Given this list of marker genes RND3, RELB, SYK, RELA, PILRA, WNT6, SLC31A2, CCL22, FAS, SLC12A5, SMPDL3B, SUSD6, IRAK3, MMP14, VASP, CYSRT1, SNX10, OSBPL3, GNAT2, EEIG2, GSR, NFKBIE, ZBP1, SEPTIN12, NFE2L1, HCAR2, FOXN2, PIK3R6, SLC34A2, N4BP1, BCL2A1, CHRM3, SLC7A11, CLDN6, RGS9, LZTFL1, NHERF4, CFP, CAMKK1, VTI1A, RAB11FIP1 (NCBI Gene Id 80223), NXPE3, FGF23, EXOC3L4, IRF7, USP13, CFLAR, RALGDS, CEBPD, TNFAIP3, SOD2, KMT5A, PIK3CG, TRIM13, SLAMF8, ARHGEF3, TANK, TNNT1 (troponin T1, slow skeletal type), SPRN, PAQR6, NODAL, OLR1, PRRG3, KLF7, EHD1, CD69, C3, RHBDF2, CLEC5A, SAA2, UBAC2, ZDHHC5, VAMP8, SLC2A1, ADORA2A, PTPN12, SH3BP4, TMEM170B, GSC2, MLLT6, WNT7B, NOD1 (nucleotide binding oligomerization domain containing 1), ATP5PO, ZC3H12C, NLRP3, MEFV, PGPEP1L, NFKB2, TNIP1, FILIP1L, PSMD10, DNAJC22 (DnaJ heat shock protein family (Hsp40) member C22), LYPD2, STRA6, PROB1, LRP3, USPL1, GSAP, TNF, CHIC1, LELP1, ASS1, PTPN23, RAB32 (NCBI Gene Id 10981), ADRB3, ABRACL, PRRT1, IFT57 (intraflagellar transport 57), PNP, AQP12A, GOLGA7B, CACNG8, DUSP16, TP63, NUP54, ARK2C, TMA16, LMO4, GCH1, ASB6, CXCL10, CFB, GNG12, CHST1, HDC, NEK5, SLFN12, MCEMP1, EPHB2, HOOK3, HMGCS2, ST8SIA2, HDAC1, CDC42EP2, TMEM89, CYBB, SRC, HAPLN3, KANK1, LCN2, AOAH, MS4A15, TFF1, SERPINB8, ETS2, POU3F2, MGARP, ACP2, SIGLEC7, MAJIN, ABTB2, IL2RG, KIF3C, UTF1, DLGAP1, TFEC, HCK, RNASET2, ZC3H12A (zinc finger CCCH-type containing 12A), SIRPB1, NFKBIZ, LRRC17 (leucine rich repeat containing 17), ACSL5, PLEK, CCL4, NFKBIA, FOXL2, REST, MISP, CD274, AK4, IL1B, ACP5, PTGES, OPA3 (NCBI Gene Id 8186), CXCL3, SOCS3 (suppressor of cytokine signaling 3), TNFAIP2, HLA-B, CCDC88B, TRAF1 (NCBI Gene Id 7185), HIVEP1, CD38, FRMPD1, SAMSN1, CSF3, ACSL1, COL4A6, BNIPL, TRPM2, BIRC3, ACOT9, CYP2B6, SEMA4A, RHOQ, SLC16A10, RILPL2, PDE4B, JAK2, DND1, here is a description of the gene set: from publication Ochiai K, Maienschein-Cline M, Simonetti G, Chen J, Rosenthal R, Brink R, Chong AS, Klein U, Dinner AR, Singh H, Sciammas R (PMID 23684984) Genes down-regulated in at day 0 B cell IRF4-KO versus at day 0 B cell wildtype. Temporal analysis of B cell activation in vitro using CD40L and IL-2/4/5 cytokines in wild type Irf4+/+ B cells or in mutant Irf4-/- B cells harboring a tet-inducible allele of Irf4. IRF4 expression was restored, or not, in the Irf4-/- background by culturing in the presence of low or high concentrations of doxycycline. The results provide insight in the role of IRF4 expression levels in coordinating different programs of B cell differentiation. Human Gene Set: GSE46606_IRF4_KO_VS_WT_UNSTIM_BCELL_DN studied in species Homo sapiens